The following is a description of a gene set: species: Mus musculus Mouse Gene Set: GOBP_NEGATIVE_REGULATION_OF_T_CELL_RECEPTOR_SIGNALING_PATHWAY Any process that stops, prevents, or reduces the frequency, rate or extent of signaling pathways initiated by the cross-linking of an antigen receptor on a T cell., and this is the list of marker genes: Btn2a2, Dusp22, Thy1, Itpripl1 (inositol 1,4,5-triphosphate receptor interacting protein-like 1, NCBI Gene Id 73338), Cd160, Lilrb4a, Prnp, Dgkz, Pawr, Sh2d1a, Laptm5, Phpt1, Ptpn2 (NCBI Gene Id 19255), Pvrig, Ubash3a, Btrc, Lilrb4b, Ptpn6, Elf1 (E74 like ETS transcription factor 1), Ptpn22, Ezr, Ceacam1, Lgals3, Ptprj, Dusp3, Btnl2, Sla2, Nck1, Cblb